The following is a description of a gene set: from publication Wei G, Wei L, Zhu J, Zang C, Hu-Li J, Yao Z, Cui K, Kanno Y, Roh TY, Watford WT, Schones DE, Peng W, Sun HW, Paul WE, O'Shea JJ, Zhao K (PMID 19144320) Genes down-regulated in comparison of Th17 cells versus naive CD4 T cells. Human Gene Set: GSE14308_TH17_VS_NAIVE_CD4_TCELL_DN species: Homo sapiens Multipotential naïve CD4+ T cells differentiate into distinct lineages including T helper 1 (Th1), Th2, Th17, and inducible T regulatory (iTreg) cells. The remarkable diversity of CD4+ T cells begs the question whether the observed changes reflect terminal differentiation with heritable epigenetic modifications or plasticity in T cell responses. We generated genome-wide histone H3 lysine 4 (H3K4) and lysine 27 (H3K27) trimethylation maps in naïve, Th1, Th2, Th17, iTreg, and natural (n)Treg cells. We found that although modifications of signature cytokine genes (Ifng, Il4, and Il17) partially conform to the expectation of lineage commitment, critical transcription factors such as Tbx21 exhibit a broad spectrum of epigenetic states, consistent with our demonstration of T-bet and IFN-gamma induction in nTreg cells. Our data suggest an epigenetic mechanism underlying the specificity and plasticity of effector and regulatory T cells and also provide a framework for understanding complexity of CD4+ T helper cell differentiation., and this is the list of marker genes: ALG1, AKNA, TOX3, KLHL40, TRAM2, CYP8B1, TBXA2R, RELN, BTK, NPY4R, TMEM132E, ORAI1 (NCBI Gene Id 84876), DEAF1, CLCN4, NCCRP1, EPC2, DNASE1L2, CAD, PI4KA, NSUN5, FGFRL1, TIMP2, GPR146, SMPD5, PKD1, NAGPA (NCBI Gene Id 51172), TENM1, CASKIN1, ATG3, GJD2, ADCY6, OLFM1, ANO1, CHIC1, SPATA31F1, MYO9A, POU5F2, NHERF4, GBP6, BAHD1, SLC22A16, RRM2B, NOX4, SLC39A10, C19orf53 (NCBI Gene Id 28974), PRKCD, LTO1, ARL13A, HIVEP3, RPAIN, CLIP1, ESCO1, ZNF598, CAPN15, SLC22A5, TMEM179B, GIGYF2, SMPD2, ERI1, TCOF1, RNPS1, IFIH1, ART4, EPS8L1, NAT14, GIMAP4, EMC1, NR4A1, HSPD1, CLCN2, TARS2, RHOG, VAC14, ZBTB6, TAPT1, CCND2 (NCBI Gene Id 894), AAMP, PIP5K1A, PAN3, INIP, ERCC5, CENPJ, RIGI, CD5 (NCBI Gene Id 921), RTEL1, LDB1, ALG14, GRAMD1B, NRSN1, DCLK1, CXCL17, AFF1, SP6, CCL4, ABCA7, COL11A2, GALNT4, EVL, ST6GALNAC1, NPR3, DYNC1H1, ZZEF1, CACNA2D4 (NCBI Gene Id 93589), LGI2, RRP9 (ribosomal RNA processing 9, U3 small nucleolar RNA binding protein), DMRTA1, BMP5, PTPN12, LSM14B, TBX5, MFHAS1, GUCD1, POLR2A, ACTL10, RAB3B, MAP3K3, EIF2B5, PARP2, CHD7, ADAMTS6 (ADAM metallopeptidase with thrombospondin type 1 motif 6), TRIT1, PGAP1, RNASEH2C, FAF2, EIF1B, DDI1, POLE2, SHMT1, ITGA10, KRT2, RGL2, PPM1B, ZNF444, CNEP1R1, UPP2, PDSS2, AFP, GABRR2, CCNL2, NELFA, DFFB, METTL3, MPHOSPH8, BBOF1, FBXL5, LIMK2, ZNF687, LSM7, JAK1, IRF9, RDH13, ZNF507, DENND6B, HMGXB4 (HMG-box containing 4), CHD4, SLC6A9, FMNL3, SORT1 (sortilin 1), CTSD, FAM120B, ASB6, VPS16, NMNAT2, ATF4, CUL5 (NCBI Gene Id 8065), FAM86B2, DPM1, NPC2, C1orf174, LENG9, OPRD1, EFCAB14, PAXX, FAM234B, PRPSAP2, MORC3, TCTN3, PGM2L1, SEC14L5, SFXN2, DCAF1, TRIAP1, TFCP2, ZFP36, WDR64, XPO6 (exportin 6), DNAJB11, FUS, CNOT2, GBX1, EWSR1, ACP5, CYB5R2, PPIE, PRKAG3, MTSS1, GPATCH2, PTPRC (protein tyrosine phosphatase receptor type C), MAPK14 (NCBI Gene Id 1432)